The following is a description of a gene set: Mouse Gene Set: GOBP_NEGATIVE_REGULATION_OF_CELL_JUNCTION_ASSEMBLY Any process that stops, prevents or reduces the frequency, rate or extent of cell junction assembly. studied in species Mus musculus, and this is the list of marker genes: Gsk3b, Robo1, Dkk1, Acvrl1, Clasp2, Ikbkb, Rock1, Mdga1, Clstn3, Tlr2, Il1b, App, Tnf (NCBI Gene Id 21926), Ace, Lrp1, Src, Rcc2, Arhgap6, Rock2, Dlc1, Epha7, Rps6, Cbln1, Coro1c, Fam107a, Rhoa, Slit1, Mmp14, Pten, Phldb2, Ptpn13, Rps6-ps4, Dusp22, Dmtn, Apod, Ptk2, Wnt5a (NCBI Gene Id 77565), Itgb1bp1